The following is a description of a gene set: Human Gene Set: GCCNNNWTAAR_UNKNOWN Comprehensive identification of all functional elements encoded in the human genome is a fundamental need in biomedical research. Here, we present a comparative analysis of the human, mouse, rat and dog genomes to create a systematic catalogue of common regulatory motifs in promoters and 3' untranslated regions (3' UTRs). The promoter analysis yields 174 candidate motifs, including most previously known transcription-factor binding sites and 105 new motifs. The 3'-UTR analysis yields 106 motifs likely to be involved in post-transcriptional regulation. Nearly one-half are associated with microRNAs (miRNAs), leading to the discovery of many new miRNA genes and their likely target genes. Our results suggest that previous estimates of the number of human miRNA genes were low, and that miRNAs regulate at least 20% of human genes. The overall results provide a systematic view of gene regulation in the human, which will be refined as additional mammalian genomes become available. species: Homo sapiens from publication Xie X, Lu J, Kulbokas EJ, Golub TR, Mootha V, Lindblad-Toh K, Lander ES, Kellis M (PMID 15735639) Genes having at least one occurrence of the highly conserved motif M95 GCCNNNWTAAR in the regions spanning 4 kb centered on their transcription starting sites. The motif does not match any known transcription factor binding site., and this is the list of marker genes: MMP24, ERG, HMGA2, HTN1, TAMALIN, H2AX, TMCC1, KCP, PTCHD4, RALGPS2, TOX2, HROB, RUNX1T1, C6orf62, GGA1, PDGFB, FYN, SLC25A10, MMP9, MSX1, TPP1, MPP2, PHEX, RPP21, OPN1LW, ARID1A, FGF9, ABCA1, ADAMTS5, INO80, OTP, DNAJC22, EPB41L5, MN1, NKX2-5, VAX1, GNAQ, KYAT1, DPF3, RBMX, FAM117A, HOXB8, DAB1, IMPDH2, SOCS2, EGR1, ALPL, SOX5, CAMK2D, UBE2D3, ASGR1, FOXP2, INPPL1, CCER1, CA14, ERRFI1, VCL, EGFL6, RAB33A, VASP, RPL10, CTDSP1, MAGI1, SOX4, SIK3, EN2, CADM1, CELF4, IER5L, DUSP5, HOXA10, C1orf43, ATP5MC2, ATOH1, PTMA, ALPK2, CSDE1, MITF, NFIL3, ELAVL4, PTCH1, SZRD1, DGKI, CBX6 (NCBI Gene Id 23466), ABCC5, PEX5, NDUFAF3, MEF2D, SLC2A14, TGFB3, EML4, NECAB3, ITGA3, FHL3, JPH4, ZBTB18, LRP5, ISL1, TBCC, STK35, PPARGC1A, HPS3, PHOX2B, PITPNA (phosphatidylinositol transfer protein alpha), TMEM59L, PCGF1, SHH, SCUBE3, BCL9, ETV6, PTGR3, NPR3 (NCBI Gene Id 79614), MID1 (NCBI Gene Id 8230), KCNH3, RFX4, ITPR1, HPSE2, SLC39A5, HOXA4, RALGAPA1P1, ADAM12, BHLHE41, OPCML, PTPRG, SFTPC, CCDC126, OTX1, LDHD, NFATC4, CDKN2C, SLC5A7 (solute carrier family 5 member 7), KLC2, GDNF, DALRD3, ZFP82, GYG1, TRIB2, XPO7, KCTD15, DMPK, MIR17HG, NPTX1, FSBP, USB1, STON2, CDKN1B, HTR2C, FES, ETV5, NDRG2, COCH, SFXN5